The following is a description of a gene set: The chemical reactions and pathways involving fructose 2,6-bisphosphate. The D enantiomer is an important regulator of the glycolytic and gluconeogenic pathways. It inhibits fructose 1,6-bisphosphatase and activates phosphofructokinase. studied in species Mus musculus Mouse Gene Set: GOBP_FRUCTOSE_2_6_BISPHOSPHATE_METABOLIC_PROCESS, and this is the list of marker genes: Pfkfb3, Pfkfb2, Tigar, Pfkfb1, Pfkfb4, Gck